The following is a description of a gene set: Human Gene Set: GOBP_REGULATORY_T_CELL_DIFFERENTIATION species: Homo sapiens The process in which a relatively unspecialized T cell acquires specialized features of a regulatory T cell. Regulatory T cells control or suppress immune responses through a variety of mechanisms and subsets include the CD4+CD25+ cell type as well as certain CD8+ cell types., and this is the list of marker genes: CD46, CD28, HLA-G, IFNG, IL2RG, KLHL25, KAT2A, SOCS1, IL2, IRF1, HLA-DRA, SOX12, PSG9, KCNK18, MDK, LILRB2, KAT5, TOX (NCBI Gene Id 9760), FANCA, LCK (NCBI Gene Id 95387), HLA-DRB1, DROSHA, FUT7, LILRB4, DUSP10, LAG3, AMBRA1, FOXP3, LGALS9, TNFSF4, VSIR, USP44, CTLA4, CR1, FOXO3, MIR21, BCL6, TGFB1, IL4I1, MIR30B, BTN2A2, PLA2G2D, FANCD2